Given this list of marker genes Lcor, Txnrd3, Psmd11, Gfer, Mapt, here is a description of the gene set: Genes predicted to be targets of miRBase v22 microRNA mmu_miR_615_3p in miRDB v6.0 with MirTarget v4 prediction scores > 80 (high confidence targets). Mouse Gene Set: MIR_615_3P studied in species Mus musculus from publication Chen Y, Wang X (PMID 31504780)